Given this list of marker genes ING2, MBD2, SETD5, CDK2AP1, SAP130, RERE, KDM3A, RUVBL2, SAP30, BRD8, HDAC6, MTA3, HDAC3, SATB2, CSNK2A1, BRMS1L, MECOM, ING1, KMT2E, SIN3A (NCBI Gene Id 25942), NRIP1, HDAC9, SAP30L, SINHCAF, HDAC4, GATAD2B, RCOR3, TBL1XR1, HDAC11, CHD4, KDM3B, NCOR1, MTA1, MBD3, TBL1X, HDAC1, TRRAP, RCOR2, KAT5, HDAC2, CBX5, ANP32E, GATAD2A, RUVBL1, SRCAP, ZNHIT1, SAP18, ARID4A, SUDS3, MORF4L1, ARID4B, RBBP4, ZNF217, MIDEAS, ING3, RBBP7, RCOR1 (REST corepressor 1), BRMS1, HDAC7, CFDP1, CHD3, ZNF541, HR, HINT1, DMAP1, CDK2AP2, HDAC5, HDAC8, JMJD1C, TBL1Y, TET1, OGT, MTA2 (metastasis associated 1 family member 2), ACTR6, TAF6L, TRERF1, CHD5, DNTTIP1, SIN3B, PHF12, EP400, PHF21A, HDAC10, here is a description of the gene set: A protein complex that possesses histone deacetylase activity. Human Gene Set: GOCC_HISTONE_DEACETYLASE_COMPLEX species: Homo sapiens